The following is a description of a gene set: Reactome Pathway: Autodegradation of the E3 ubiquitin ligase COP1 part of: Stabilization of p53 species: Homo sapiens COP1 is one of several E3 ubiquitin ligases responsible for the tight regulation of p53 abundance. Following DNA damage, COP1 dissociates from p53 and is inactivated by autodegradation via a pathway involving ATM phosphorylation of COP1 on Ser(387), autoubiquitination and proteasome mediated degradation. Destruction of COP1 results in abrogation of the ubiquitination and degradation of p53., and this is the list of marker genes: PSMD7, PSMB4, PSMC5, PSMD14, PSMA3, PSMC1, PSMD2, ATM, UBB, PSMA7, PSMD1, PSMA2, PSMB5, PSMB7 (NCBI Gene Id 5695), PSMB3, ADRM1, UBA52, SEM1, PSMD3, PSMD11, PSMC4, PSMD12, PSMA4, PSMB6, TP53, PSMD6, PSMA6 (NCBI Gene Id 87553), RPS27A, PSMB2, PSMD13, UBC, COP1, PSMA1, PSMA5, PSMC6, PSMB1, PSMD8, PSMC3 (NCBI Gene Id 96121), PSMC2